Given this list of marker genes ELANE, DDX20, GUSB, DHX37, AGPAT5, APIP, DNLZ, TMEM186, PLAA, SIGLEC5, THOC5, MAOA, FAM149B1, MDH1, ABRAXAS1, PYCARD, CCNQ, TEX2, SDF2L1, WDR73, MAPKAPK3, TAMM41, SNUPN, EEF1B2, DESI2, MYG1, DYNC2I2, RABEPK, PSMA3, MRPL12, GALK1, PES1, GFM1, CBLN3, TXNDC15, SSR2, TRMT6, POLR3E, PRAG1, MRPS25, SMIM40, ARMT1, YDJC, MTG1, SSR1, RPN1, CISD1, DBI, APEX1, TRAPPC13, AAGAB, C7orf50, TBRG4, TMEM97, ERP44, AS3MT, BET1, BLOC1S2, SEL1L2, SLC35B2 (solute carrier family 35 member B2), CDADC1, LMAN2, ZNF266, PAPSS2, SPCS3, GMPPA, CASP7, ERLIN1, AP3S2, PLAC8, GCNT3, FANCM, MAP3K20, DTX4, ABI3, MFSD10, G3BP1, AHCY, CUL5, RSU1, ENOPH1, POLR3C, GPR180, NOL9, BID, UTP25, BLOC1S4, PARL, MRPS35, NOC3L, COMMD10, TNS3, ATL3, PFKP, NPC2, PCCA (NCBI Gene Id 5095), QARS1, ERMARD, NAA50 (N-alpha-acetyltransferase 50, NatE catalytic subunit), SCO1, SCIN, EIF6, AFAP1, ZNF583, ALDOA (aldolase, fructose-bisphosphate A), CTSZ, ATP6AP2, ISG20L2, CLUAP1, SFXN4, TMEM178A, PGAM1, KIAA0825, ELP2, ZNF706, NEBL, CITED2, MAPRE2, RASSF4, SURF6, CEBPZ, PLA2G4D, NIPSNAP3A, UBFD1 (NCBI Gene Id 56061, ubiquitin family domain containing 1), CHST14 (NCBI Gene Id 89881), WDR77 (WD repeat domain 77), DDX52, ERCC8, NOSTRIN, GTF3A, KLHL23, LUC7L, GTPBP8, CHCHD4, GPT2, here is a description of the gene set: from publication Ivanova NB, Dimos JT, Schaniel C, Hackney JA, Moore KA, Lemischka IR (PMID 12228721) Human Gene Set: IVANOVA_HEMATOPOIESIS_INTERMEDIATE_PROGENITOR Mechanisms regulating self-renewal and cell fate decisions in mammalian stem cells are poorly understood. We determined global gene expression profiles for mouse and human hematopoietic stem cells and other stages of the hematopoietic hierarchy. Murine and human hematopoietic stem cells share a number of expressed gene products, which define key conserved regulatory pathways in this developmental system. Moreover, in the mouse, a portion of the genetic program of hematopoietic stem cells is shared with embryonic and neural stem cells. This overlapping set of gene products represents a molecular signature of stem cells. Genes in the expression cluster 'Intermediate Progenitors Shared': up-regulated in hematopoietic intemediate progenitor cells from adult bone marrow and fetal liver. species: Mus musculus